Given this list of marker genes FSHR, GPHA2, CGA, GNRH2, LHB, GNRH1, GNRHR (gonadotropin releasing hormone receptor), LHCGR, FSHB, TSHR, GPHB5, TSHB, here is a description of the gene set: Human Gene Set: REACTOME_HORMONE_LIGAND_BINDING_RECEPTORS Hormone ligand-binding receptors species: Homo sapiens